The following is a description of a gene set: A DNA repair process that is initiated by an endonuclease that introduces a single-strand incision immediately 5' of a UV-induced damage site. UV-damage excision repair acts on both cyclobutane pyrimidine dimers (CPDs) and pyrimidine-pyrimidone 6-4 photoproducts (6-4PPs). Mouse Gene Set: GOBP_UV_DAMAGE_EXCISION_REPAIR studied in species Mus musculus, and this is the list of marker genes: Pola1, Rad23b, Ddb2, Pold3, Actr5, Sirt1, Ino80, Ddb1, Rad23a, Xpc, Xpa, H2ac25, Ercc1, Trex1, Mc1r, Cul4b